Given this list of marker genes USO1, SQLE, CYRIA, KLF6, SLAMF8, TNIP1, RNPEP, BCL10, ZFAND5, DUSP4, SNX29, FPR2, ETS2, PLK2, TRIO, FAM20C, PTGER4, PLGRKT, FABP4, EGR1, IGF1, GDPD1, DRAM1, MS4A7, CRELD2, ZC3H12C, TMEM176A, FMNL2, RGS3, EIF1AY, KLF13, C1QC, PRXL2B, BRI3, RNF19A, HGSNAT, IDE, MYO10 (myosin X), SOD2, STAB2, MYH10, OPTN (optineurin), PLD3, H1-2, ICAM1, NEAT1, FAM3C (FAM3 metabolism regulating signaling molecule C), ALG1, P3H3, MCOLN2, VPS29, EHD1, CCDC115, AOAH, LMBR1, IGF2BP2, ANXA4, ARID1A, HSPA5, HIF1A, MMP13, SYN1, BIRC3, SORL1, IFNAR1, SHMT1, SEMA4D, HP, UTP25, TTLL11, SELENOS, CPSF2, GPR180, RBPJ, NAA25, TMEM205, SLC11A2, AIRN, RUFY1, GPR162, HYOU1, WSB2, CYB5R1, UBE2F, PLA2G7, MCUR1, STK40, SLCO3A1, BASP1, SLC35B1, KLF7, P2RX4, MLLT6, ANXA5, ADAM19, LARP1, SEC24D, ETV5, AZIN1, PLEK, FGD3, CXCL3, PRR5L, RALGDS, HIVEP3, LACC1, TTC39B, ANO10, FABP5, SERPINB8, TLR2, RAP2B, TMEM176B, DHCR24, IL1RN, NINJ1, PDIA6, MAN1A1, PSMA3, PTMS, HNRNPD (heterogeneous nuclear ribonucleoprotein D), PINX1, CIAPIN1, ADGRL2, TRMT61A, MOCOS, LRCH3, ACOD1, CLEC6A, TMEM178A, TRAF1, DHRS11, SNX2, RASSF4, COPG2IT1, ISG20L2, ATF3, RAB20, ADAM17, N4BP1, PSTPIP2, SAV1, RNF2, DPH6, PFKFB3, ACP2, CLCN7, HAPSTR1, NAP1L4, MARCKSL1, CTSZ, DDHD1, TFRC, CWC22, TPM3, GPR84, C3, CCND1, AGPAT2, ITM2B, NLRP3, NFIX, CYFIP1, CBL, CSF3R, ITGA9, NADK, CASP1, CITED2, NFKBIA, GREM2, MMP14, PLD2, RFFL, ZFP90, SLC48A1, MIR99AHG, NAB1, DIAPH2 (diaphanous related formin 2), TNFAIP3, CD82, NAGK, RELB, DNAJB11, CD22, SLC15A3, MANF, RUFY3, PLXNA2, FNBP1L, ATRNL1, SAA1, CASP4, NFKBIE, MMP12, HPSE, TASOR, TNFRSF1A, CCNYL1, here is a description of the gene set: species: Homo sapiens Genes down-regulated in thymic implants from fetal versus those from adult bone marrow. from publication Mold JE, Venkatasubrahmanyam S, Burt TD, Michaëlsson J, Rivera JM, Galkina SA, Weinberg K, Stoddart CA, McCune JM (PMID 21164017) Human Gene Set: GSE25085_FETAL_BM_VS_ADULT_BM_SP4_THYMIC_IMPLANT_DN Human fetal and adult hematopoietic stem cells (HSC) were obtained from fetal liver, fetal bone marrow (BM), and adult BM. These were injected into human fetal thymic implants in SCID-hu Thy/Liv mice (4-6 separate mice per HSC donor) and allowed to mature into single positive CD4+ (SP4) thymocytes over the course of 7-8 weeks. SP4 thymocytes from injected stem cells were subsequently sort-purified from thymic implants and gene expression was performed.